The following is a description of a gene set: Human Gene Set: HP_OSTEOCHONDROSIS Osteochondrosis Abnormal growth ossification centers in children. Initially a degeneration/ necrosis followed by regeneration or recalcification. species: Homo sapiens, and this is the list of marker genes: MMP13, ACTG1, COL9A2, SMAD3, FGFR1, KRAS, LMX1B, ORC1, ACAN (NCBI Gene Id 404712), SMAD2, ACTB, DYRK1A